Given this list of marker genes MAPK14, CACNA1H, CD81, ADAMTS5, ADAMTS15, PTGFRN, GDF15, MYOG, ITGB1, ADGRB1, MYH9, DOCK5, ADGRB3, NOS1, TMEM182, DOCK1, CDON, CFLAR, EHD1, NEO1, CAPN2, ERVW-1, EHD2, CACNA1S, CAV3, TNFSF14, CCL8, ADAM12, NPHS1, CD9, MYOD1, RIPOR2, DOCK2, SCGB3A1, CXCL10, MYMK, NFATC2, WNT1, MYMX, IL4R, KCNH1, TANC1, PLEKHO1, CXCL9, ERVFRD-1, DYRK1B, CD53, FLOT1, here is a description of the gene set: studied in species Homo sapiens A process in which non-proliferating myoblasts fuse to existing fibers or to myotubes to form new fibers. A myoblast is a mononucleate cell type that, by fusion with other myoblasts, gives rise to the myotubes that eventually develop into skeletal muscle fibers. Human Gene Set: GOBP_MYOBLAST_FUSION